The following is a description of a gene set: To elucidate the gene expression “footprint” of antigenically challenged T-cells which had been treated with anti-LFA-1, CTLA4Ig, anti-CD40-ligand antibodies, we performed microarray gene expression analysis comparing the expression profile of costimulatory blockade treated and untreated responder T-cells. studied in species Homo sapiens Human Gene Set: GSE26669_CD4_VS_CD8_TCELL_IN_MLR_UP Genes up-regulated in comparison of untreated CD4 T cells versus the untreated CD8 T cells. from publication Pearl JI, Lee AS, Leveson-Gower DB, Sun N, Ghosh Z, Lan F, Ransohoff J, Negrin RS, Davis MM, Wu JC (PMID 21362570), and this is the list of marker genes: IRAK2, FAM118A, MTMR10, B4GALT4, PSMD9, DCUN1D4, DET1, DMRTC1B, ERGIC1, PFN2, RASL11B, PFN1, ZC3HC1, PCBP4, ICOS, ZNF608, CORO7, UNC80, RABGAP1L, RNH1, CTLA4, NMUR2, CAND1, PRNP, NCMAP, RGS14, RAP1GAP, RBM38, FYN, TGDS, BAG3, RPS26, LTBP1, WDR82, SLC7A14, POLE2, TNFSF11, ARL5A, NDRG3, CKB, TES, PARP2, ARVCF, PRPSAP1 (phosphoribosyl pyrophosphate synthetase associated protein 1), ORAI1 (ORAI calcium release-activated calcium modulator 1), WNT4, MOV10, ARPC5L, GRHL1, ADCY6, DDX46, TSC22D1, JAK2, FKBP1A (NCBI Gene Id 2280), ANGPT2, PFKL, SUCO, CASP4, ANKH, HSPA14, RBM7, IL2RA, GATA3, BEND6, CSGALNACT1 (NCBI Gene Id 55790), SYNPO2, ASAP1, CDIPT (NCBI Gene Id 10423), FUOM, MAP4K3 (mitogen-activated protein kinase kinase kinase kinase 3), ZNRF1, GCAT, GPAT4, CITED2, TNFRSF9, PTPN2, AARS1, KLHDC2, CSTF3, MAGED1, SLC25A40, PRDX4 (peroxiredoxin 4), AREG, TNFRSF18, LEFTY1, STXBP1, SLC2A10, SRSF7, BCL2, PAQR3, DHRS4, FAM133B, KCNH2, RCAN3, CTDSP2, NAMPT, ACVR1B, IFIT2, NUDT4, NDUFAF3, FAF2, CREB3L2, TMF1, DNAJC10, GIMAP4 (NCBI Gene Id 55303), GPRASP1, FUT8, BMP15, RCSD1, RB1, FAM20B, AVEN, HAGHL, RRAGD, OSBPL9, KCNMB4 (potassium calcium-activated channel subfamily M regulatory beta subunit 4), SMCO3, CPM, PPA1, LIX1L, ZNF823, STAT5B, TMCC1, PPP1R16A, C19orf12, AHR, REC114 (REC114 meiotic recombination protein), KRT27, ALG2, TENT5C, CNST, LONRF3, EAF2, NFIC, DAP3 (death associated protein 3), TIMP3, KLC3, PAPSS1, SLC25A1, PRDM1, GRHL2, GABARAPL2, PARP8, SLC25A24, MINDY3, EIF4E3, CENPN, FDFT1, RBX1, NCAM2, GPT, UBR4, MYO10, SAMD1, SAG, PSMD3, PIGC, FMNL2, HK1, RGS10, GTF2A2, ETS2, PRKCA, EXOC3, CHAD, ZCRB1, CISH, DGCR6, DACH1, LONP2, RNF7, RASGRP1 (RAS guanyl releasing protein 1), OAS2, MAPK11 (mitogen-activated protein kinase 11), ITM2A, DOK2, NRP1, CAPG, GTF3C6, MANF, ZBTB7B (zinc finger and BTB domain containing 7B), EFNA4, HSPA5, GIPC1, BDH1, BYSL (NCBI Gene Id 705), DGAT1, RCN1, HNRNPA0, ALG14, ALDH7A1, LRP8, MAPK9, LHPP, MKLN1, PLAGL1, TBCE, LSM4 (NCBI Gene Id 25804), USP29, HEYL